Given this list of marker genes TTC7A, EDN3, LRP5, FOXE1, MYO5B, SMPD1, CLMP, SLC9A3, SPIB, SEC63, COX11, KIAA0753, ERBB3 (NCBI Gene Id 619500), MPV17, SLC26A4, ITGB4, DYNC2H1, NKX2-5, SLC26A2, HLA-DQA1, LBR, PIGA, TXNDC15, MYLK, PHOX2B, FRG1, COL2A1, SLC5A1, SEMA3C, ALAD, BMPER, ATP1A2, POLG, FREM2, PI4KA, IFT56, ALK, KRT18, MYH11, MNX1, NPHS1, STAT4, EPCAM, DYNC2I2, PSAP, NKX3-2, ARSA, HMBS, NRTN, COL11A1, TCTN2, SLC35D1, EPHB4, PTH1R, INPPL1, SI, FLNA, PYGL, INSR, PAX8, EDNRB, NKX2-1, TSHR, LIPA, SLC37A4, RET, GNPTAB, IFT80, ACTG2, CHD8, EPB42, IFT52, EWSR1, FBN1, SPINT2, TFAM, ABCD1, SLC26A3, HACE1, TYMP, LIN28B, LMO1, TRMU, SLC2A2, G6PC1, STX3, LIG3, CYP27B1, SMARCAL1, ATP7B, IL12RB1, KAT6A (NCBI Gene Id 7994), C2orf69, SEMA3D, PRKCSH, BRCA1, DDRGK1, SMO, FLI1, ALG8, DLK1, TRIP11, HLA-DQB1, IPO8, GNE, TNPO3, VDR, FSHR, MYL9, AGR2, DHCR7, FLNB, SLC1A3, ANO1, ECE1, PSMB8, DLL3, MEG3, ATP7A, DUX4, MYCN, DUX4L1, IL12A, ALDOB, SPP1, CACNA1A, TREH, MMEL1, WDR35, SMCHD1, RTL1, ATP1A3, IFT122 (NCBI Gene Id 55764), MESP2, CYP2R1, GNPNAT1, DYNC2I1, DYM, SPTA1, LYSET, IRF5, COL11A2, IRAK1, PLEC, MTOR, FOCAD, ANK1, RRM2B, SAT1, LMOD1, POU2AF1, PSAT1, ITGA6, GUSB, PERCC1, SLC4A1 (solute carrier family 4 member 1 (Diego blood group)), SAR1B, SPTB, IDUA, ERBB2, POLG2, ZEB2, DICER1, GDNF, SREBF1, FGFR3, DNMT3B, GBA1, TNFSF15, WT1 (WT1 transcription factor), here is a description of the gene set: Abdominal distention Human Gene Set: HP_ABDOMINAL_DISTENTION Distention of the abdomen. species: Homo sapiens